Given this list of marker genes Gorab, Grm5, Uqcc4, Mtch2, Rbfox1, Memo1, Kera, Gpm6b, Ywhaz, Gpc6, Ociad1, Pnma3, Ryr3, Zfp36l2, Glg1, Brcc3, Ntrk3, Acr, Ppl, Lca5, Ptprm, Jpt2, Klf1, Xpo1, Dspp, Plppr1, B4galnt2, Selenos, Prkca, Gpr155, Agpat3 (1-acylglycerol-3-phosphate O-acyltransferase 3), Papola, Arfgef1, Ubn1, Aldh5a1, Med4, Oscp1, Smad9, Snx16, Phf5a, Kcnb1, Nrxn3, Sp2, Ktn1, Luzp2, Il1a, Fabp5, Dera, Ibsp, Cfap418, Rnase10 (ribonuclease, RNase A family, 10 (non-active)), B3galnt2, Mindy2, Celf1, here is a description of the gene set: from publication Chen Y, Wang X (PMID 31504780) Mouse Gene Set: MIR_7230_3P Genes predicted to be targets of miRBase v22 microRNA mmu_miR_7230_3p in miRDB v6.0 with MirTarget v4 prediction scores > 80 (high confidence targets). studied in species Mus musculus